The following is a description of a gene set: Binding to a diacylglycerol, a diester of glycerol and two fatty acids. Human Gene Set: GOMF_DIACYLGLYCEROL_BINDING species: Homo sapiens, and this is the list of marker genes: UNC13C, FITM2, PRKCA, RASGRP4 (NCBI Gene Id 115727), UNC13B, RASGRP1, PLTP, RASGRP2, RASGRP3, RAPGEF2, UNC13A, DGKD, FITM1, CHPT1, CDIPT